Given this list of marker genes ATAD2B, ITGB1, BCAS3, SPSB3, OSBPL2, NAT9, ZBTB45, NAA30, PAXIP1, SLC18A1, HADH, ZNF841, TMEM140, GRM1, GIGYF1, SEPTIN4, MYLIP (NCBI Gene Id 29116), TMEM183A, ATP2C1, RAP2A, ZNF623, NKAIN1, MLF1, SLTM, NR2F6, HES5, SDHAF1, MORF4L1, RETREG2, TESK2, SMAD5, FCER2, HNRNPDL, MPHOSPH9, BAK1, WNT7B, P2RX3, DDX3Y, SPRTN, UNC5C, COL6A3, SUMO3, CACNG6, PFKP (NCBI Gene Id 5214), GSPT2, ENKD1, ZC3H7A, ANGEL2, IRX5, DENND2B, SLF2, ZNF688, PTP4A2, EIF4B, YKT6, ERAP1, ARPC1A, TMEM186, RPLP1, OGFOD2, VPS9D1, MAN2B2, OXR1, MED17, PLEKHS1, MIF4GD, CSNK1D, C22orf39, ZNF436, HAUS5, ANLN, GCC1, PCBP2, SYNE4, CRK (CRK proto-oncogene, adaptor protein), CAPN2, POMGNT1, TRAF2, IQGAP1, SC5D, ERG28, SIK1, VKORC1, PPP3CA, RABGAP1, PSRC1, CNOT6, ING2, NHEJ1, SIMC1, OSBPL11, RPS6KB2, ZNF319, ALG2, CGGBP1, CDC37L1, KCTD11, MAGED1, PDGFC, ZC3H14, BRDT, OXSR1, KLF10, CYP4A22, RNF214, ASF1B, PNLIPRP1, SCMH1, MTF1, P2RX4, HASPIN, RBBP4, RAD23B, ARMC10, ZFP90, TM6SF1, TXNIP, CRLF3, PTMS, SENP3, TUT1, BAZ1B, CDK2AP2, BMS1, SCX, MAN1A2, PPIL4, PIP5K1C, LAMTOR1, CYBC1, GADD45G, MRPL49, GALT, PPP4R3A, NAPG, AGR3, CYP51A1, AIRN, VPS37A (NCBI Gene Id 23687), REPIN1, TPX2, FBXO9, ETFBKMT, FANCE, MAPK10, KRTAP21-1, MYBL2, GLB1L, CCNE1, PLEKHN1, FASTKD5, EQTN, RAB4B, SIRT3, FGF22, SOX4, CLNS1A, CREBZF, TBRG4 (NCBI Gene Id 9238), ALDH18A1, PTGER2, NOP53 (NCBI Gene Id 94457), SRI, POLR2B, TADA1, KARS1, B3GNT8, NUDCD3, LIMK2, MFNG, N4BP3, UBN1, H3C4, EIF4A1, ABHD17A, ADAM15, HNRNPLL, IRAK4 (NCBI Gene Id 95458), STMN1, HIP1R, KCNA6, FDFT1, EMC3, PAQR7, DCTN2, ZMIZ2, PLEKHO2, THRSP, EYA1, TOMM40L, TAMALIN, NECAP2, ATG12 (NCBI Gene Id 9140), BABAM1, GNAI3 (G protein subunit alpha i3), TRAPPC14, AP2S1, CAPZA2, TMBIM6, NDUFS2, here is a description of the gene set: Genes up-regulated in comparison of control dendritic cells (DC) at 1 h versus those stimulated with LPS (TLR4 agonist) at 1 h. Human Gene Set: GSE17721_CTRL_VS_LPS_1H_BMDC_UP from publication Amit I, Garber M, Chevrier N, Leite AP, Donner Y, Eisenhaure T, Guttman M, Grenier JK, Li W, Zuk O, Schubert LA, Birditt B, Shay T, Goren A, Zhang X, Smith Z, Deering R, McDonald RC, Cabili M, Bernstein BE, Rinn JL, Meissner A, Root DE, Hacohen N, Regev A (PMID 19729616) species: Homo sapiens mouse primary BMDCs were stimulated with tlr ligands and gene expression changes were profiled on Affymetrix arrays